Given this list of marker genes GNAT1, RHO, PDE6H, PROM1, CNGA1, PHLPP2, PDE6G, ROM1, NAPEPLD, PRCD, GUCY2D, PDE6A, GNAT2, CDHR1, PDE6B, DHRS3, here is a description of the gene set: Human Gene Set: GOCC_PHOTORECEPTOR_OUTER_SEGMENT_MEMBRANE studied in species Homo sapiens The membrane surrounding the outer segment of a vertebrate photoreceptor.